The following is a description of a gene set: Mouse Gene Set: GOBP_PLASMA_MEMBRANE_PHOSPHOLIPID_SCRAMBLING The movement of a population of phospholipid molecules from one leaflet of the plasma membrane bilayer to the opposite leaflet, resulting in loss of lipid asymmetry and surface exposure of phosphatidylserine (PS) and phosphatidylethanolamine (PE). studied in species Mus musculus, and this is the list of marker genes: Atg9a, Plscr1, Plscr1l1, Vdac2, Ano3, Fasl, Plscr4, Atg9b, Trpc5, Plscr3, Xkr6, Xrcc4, Ano6, Serinc5 (NCBI Gene Id 97832), Serinc2, Slc4a1 (NCBI Gene Id 20533), Xkr9, Xkr8, Ano7 (anoctamin 7), Vmp1, P2rx7, Serinc3, Ano9, Ano4, Plscr2, Tmem41b, Clptm1l, Xkr4, Xkr7, Plscr5